The following is a description of a gene set: Erythropoietin activates Phosphoinositide-3-kinase (PI3K) species: Homo sapiens Human Gene Set: REACTOME_ERYTHROPOIETIN_ACTIVATES_PHOSPHOINOSITIDE_3_KINASE_PI3K, and this is the list of marker genes: IRS2, EPO (NCBI Gene Id 82670), PIK3R5, JAK2, PIK3CG, PIK3R1, PIK3CB, LYN, GAB1, PIK3CD, EPOR, PIK3CA